Given this list of marker genes GGA2, ALDH3A2, HOXA9, MEF2C, TRPM4, ELF3, ITGAX, PGAM1, GOLGA8N, CCL5 (NCBI Gene Id 8147), MRPL33, LGALS1, PBX3, ALOX5AP, ADCY9, LY86, SRGN, FBP1, MRPL34, DEXI, SAGE1, MFSD1, CUL1, PLD3, RPS6KA5, KMT2A, C2, COL9A2, ANXA5, GBA1, MVP, IRAG2, APOC2, SLC9A6 (NCBI Gene Id 53362), CTSL, HEXB, ENSG00000274253, COX8A, RNASE3, RMND5B, SYT17, PREB, BLOC1S1, PYCARD, MBNL1, ALDH3B1, STXBP2, FEZ1, AKR7A2, SOCS2, TDRD7, GAS7 (growth arrest specific 7), GUSB, RNASE2, AK2, SIRPA, SPG21, RPL22, FES, CAPG, SCPEP1, MAGEF1, SNX10, HOXA5, CPM, HK3, CCL23, RNH1, GLG1, NKG7, FCGR1A, ITGA7, ACSL4, PHKA2, TPP1, XAGE1B, MICAL1, DACH1, CES1, APH1B, here is a description of the gene set: species: Homo sapiens Human Gene Set: ROSS_AML_WITH_MLL_FUSIONS from publication Ross ME, Mahfouz R, Onciu M, Liu HC, Zhou X, Song G, Shurtleff SA, Pounds S, Cheng C, Ma J, Ribeiro RC, Rubnitz JE, Girtman K, Williams WK, Raimondi SC, Liang DC, Shih LY, Pui CH, Downing JR (PMID 15226186) Contemporary treatment of pediatric acute myeloid leukemia (AML) requires the assignment of patients to specific risk groups. To explore whether expression profiling of leukemic blasts could accurately distinguish between the known risk groups of AML, we analyzed 130 pediatric and 20 adult AML diagnostic bone marrow or peripheral blood samples using the Affymetrix U133A microarray. Class discriminating genes were identified for each of the major prognostic subtypes of pediatric AML, including t(15;17), t(8;21), inv(16), MLL chimeric fusion genes, and cases classified as FAB-M7. When subsets of these genes were used in supervised learning algorithms, an overall classification accuracy of more than 93% was achieved. Moreover, we were able to use the expression signatures generated from the pediatric samples to accurately classify adult de novo AMLs with the same genetic lesions. The class discriminating genes also provided novel insights into the molecular pathobiology of these leukemias. Finally, using a combined pediatric data set of 130 AMLs and 137 acute lymphoblastic leukemias, we identified an expression signature for cases with MLL chimeric fusion genes irrespective of lineage. Surprisingly, AMLs containing partial tandem duplications of MLL failed to cluster with MLL chimeric fusion gene cases, suggesting a significant difference in their underlying mechanism of transformation. Top 100 probe sets for pediatric acute myeloid leukemia (AML) subtypes with chimeric MLL fusions.